The following is a description of a gene set: Human Gene Set: GOBP_NEGATIVE_REGULATION_OF_FAT_CELL_PROLIFERATION Any process that stops or decreases the rate or extent of fat cell proliferation. species: Homo sapiens, and this is the list of marker genes: E2F3, TFDP1, PER2, TREM2, E2F1